The following is a description of a gene set: studied in species Mus musculus Catalysis of the reaction: a carboxylic ester + H2O = an alcohol + a carboxylic anion, where the carboxylic chain has 8 or fewer carbon atoms. Mouse Gene Set: GOMF_SHORT_CHAIN_CARBOXYLESTERASE_ACTIVITY, and this is the list of marker genes: Cel, Abhd2, Abhd15, Abhd3, Abhd1, Siae, Lipc